Given this list of marker genes Arl1, Cyp2w1, Prkce, As3mt, Pam, Th, Nfe2l2, N6amt1, Fmo1, Cyp1a1, Cyp1b1, Fmo2, Cpt1a, Star, Cyp1a2, Gsta3, here is a description of the gene set: The chemical reactions and pathways involving a toxin, a poisonous compound (typically a protein) that is produced by cells or organisms and that can cause disease when introduced into the body or tissues of an organism. studied in species Mus musculus Mouse Gene Set: GOBP_TOXIN_METABOLIC_PROCESS